The following is a description of a gene set: Genes encoding transfer RNAs (tRNAs) are transcribed by RNA polymerase III in the nucleus and by mitochondrial RNA polymerase in the mitochondrion.<br>In the nucleus transcription reactions produce precursor tRNAs (pre-tRNAs) that have extra 5' leaders, 3' trailers, and, in some cases, introns which are removed by enzymes and enzyme complexes: RNase P cleaves the 5' leader, RNase Z cleaves the 3' trailer, TRNT1 polymerizes CCA onto the resulting 3' end, the TSEN complex cleaves at each end of the intron, and the tRNA ligase complex ligates the resulting exons. The nucleotides within tRNAs undergo further chemical modifications such as methylation and deamination by a diverse set of enzymes. The order of events for each tRNA is not fully known and the understanding of the overall process is complicated by the retrograde (cytosol to nucleus) transport of tRNAs.<br>In the mitochondrial matrix transcription produces long precursor RNAs, H strand transcripts and an L strand transcript, that are cleaved by mitochondrial RNase P (an entirely proteinaceous complex), ELAC2, and other nucleases to yield 12S rRNA, 16S rRNA, mRNAs, and pre-tRNAs lacking 3' CCA sequences. TRNT1 polymerizes an untemplated CCA sequence onto the 3' ends of the pre-tRNAs and chemical modifications are made to several nucleotides in the tRNAs. Reactome Pathway: tRNA processing part of: Metabolism of RNA species: Homo sapiens, and this is the list of marker genes: MT-TL2, TRMT6, MT-ND5, NUP93, FAM98B, RPP38, MTO1, RPP40, C2orf49, OSGEP, MT-TG, NUP107, TRMT61B, NUP37, CSTF2, TRMT9B, TSEN2, NUP58, TSEN15, PUS3, TRMT1, NUP62, NDC1, TSEN34 (tRNA splicing endonuclease subunit 34), MT-TS2, ELAC2, POP5, RTCB, TRMT11, NUP188, NUP85, TP53RK, HSD17B10, MT-CO1, POP7 (POP7 homolog, ribonuclease P/MRP subunit), LCMT2 (NCBI Gene Id 9836), GON7, MT-TY, DDX1, NUP210, QTRT2, TYW2, PUS7, TRMT10A, ADAT1, MT-RNR1, MT-ND2, SEC13, MT-TE, NUP35, THG1L, TRMT5, MT-TF, MT-TN, YRDC, MT-TS1, GTPBP3, RPPH1, QNG1, MT-CYB, NSUN6, RTRAF, RANBP2, NUP54, RPP30, TYW5, CLP1, TYW3, TRIT1, MT-ATP6, URM1, NUP205, MT-TK, NUP43, CDKAL1, XPOT, SEH1L, MT-TA, TSEN54, TYW1, NUP50, CPSF4, CPSF1, LAGE3, MT-TT (mitochondrially encoded tRNA-Thr (ACN)), TRMT112, MT-TW, NUP88, MT-TQ, MT-TV, CTU2, MT-ND1, NSUN2, NUP160, PUS1, POM121C, RPP25, OSGEPL1, RPP21, TRMU, DUS2, AAAS, METTL1, MT-TI, MT-TC, POM121, MT-CO3, ALKBH8, TPRKB, MT-ND3, MT-ATP8, PRORP, MT-CO2, MT-TP, CTU1, TRDMT1, MT-ND4, TRMT61A, MT-TL1, NUP133, ZBTB8OS, FTSJ1, MT-TR, NUP42, RAE1, RAN, TPR, MT-ND4L, EPRS1, QTRT1, THADA, RPP14, TRMT13, NUP153, NUP155, NUP214, MT-TM, POP1, MT-RNR2, MT-ND6, MT-TD, TRMT44, POP4, NUP98, MT-TH, WDR4, ADAT3, TRNT1, ADAT2, TRMT10C